Given this list of marker genes KIAA1755, PDZD4, PCSK5, NTN4, FAM234B, GOLT1B, NSD2, ZNF721, SPIN1, MYZAP, PSPC1 (NCBI Gene Id 55269), SMCR8, MDM1, GGNBP2, FRMD4A, ZNF84, CDK19, PRKAR2A, HMGA2, EGF, RAPH1, RTN1, ARFGAP3, ST6GALNAC3, MYO1D, HIPK3, PCDH19, UBE2QL1, CDK1, MEGF9, LRRC4, SLITRK4, VANGL1, ZDHHC17 (zinc finger DHHC-type palmitoyltransferase 17), LRRN1, KCNQ3, AK7, CUL3, HPS5, DHX15, PTGFR, FST, MIER3, TRIM36, RANBP9, LEPR, SLC35F1, TTK, FUT9, TMEM255A, THSD7B, SPIN2A, NFKBIZ, NEO1, SEMA4D, CCN3, WNK1, ZFYVE16 (zinc finger FYVE-type containing 16), CNOT4, HPGD, ATP4B, PWWP2A, SDE2, SPIN2B, SLC13A1, TENT2, DCAF13, RHAG, SIRT1, PTPN11, DNMT3B, PCGF5, ANTXR2, CYB5D1, CUL4A, CASP2, YIPF5, ATP6V1C1, PGAM1, EAF1, VGLL4, STARD4, MAFF, FRMD3, PDPN, PSD3, HAND2, CDYL2 (chromodomain Y like 2), SUSD5, DLG5, PTBP2, PTGR2, WTAP, GLT6D1, NCOA2, SPOCK3, ITGA4, LIN28B, CCL28, VEGFA, here is a description of the gene set: Genes predicted to be targets of miRBase v22 microRNA hsa-miR-3618 in miRDB v6.0 with MirTarget v4 prediction scores > 80 (high confidence targets). from publication Chen Y, Wang X (PMID 31504780) studied in species Homo sapiens Human Gene Set: MIR3618